The following is a description of a gene set: A large complex that acts as a tethering factor involved in transporting vesicles from the ER through the Golgi to the plasma membrane. A TRAPP (transport protein particle) complex has a core set of proteins which are joined by specific subunits depending on the cellular component where a given TRAPP complex is active. studied in species Mus musculus Mouse Gene Set: GOCC_TRAPP_COMPLEX, and this is the list of marker genes: Trappc13, Trappc9, Trappc8, Trappc6a, Trappc1, Trappc12, Trappc10, Trappc14, Trappc2b, Trappc2l, Trappc6b, Trappc5, Trappc11, Trappc3l, Trappc2, Trappc3, Trappc4